Given this list of marker genes Dag1, Lamc1, Lamb2, Nid1, Lama1, Clasp1, Lama2, Phldb1, Clasp2, Phldb2, Lamb1, here is a description of the gene set: Any process that modulates the frequency, rate or extent of the assembly, disassembly or arrangement of constituent parts of the basement membrane. studied in species Mus musculus Mouse Gene Set: GOBP_REGULATION_OF_BASEMENT_MEMBRANE_ORGANIZATION